Given this list of marker genes Svs4, Neurog1, Pgk2, Cdk4, Ihh, H2ax, Irs3, Tfrc, Kif20a, Eef2, D8Ertd738e, Edn1, Eif4a1, Skp1, Grin1, Gm20815, Rbm4, Tpbpa, Col4a1, Msh3, Eprs1, Rap2b, Phkg2, H1f2, Acly, Gng12, Prpf6, Polr2g, Fut4, Slc6a8, Cyp3a11 (cytochrome P450, family 3, subfamily a, polypeptide 11), Pml, Ifna15, Eif2s1, Cacnb2, Usp9x, Il17a, Ddr2, Nfe2l2, Lmnb2, Kcnh1, Zbtb16, Galt, Serpina6, Bub3, Calm3, Rela, Apoc4, Alox5ap, Kif5b, Fzd5, Itgb4, Chrm4, Rac1, Cyp19a1, Dusp7, Cntn3, Foxn1, Zyx, Xpc, Chka, Mdk, Ccl12, Iars1, Gng2, Sec23a, Eef1d, Atp5pb, Top3b, Atp2a2, Apob, Ptpn14, here is a description of the gene set: Ageing of the brain leads to impairments in cognitive and motor skills, and is the major risk factor for several common neurological disorders such as Alzheimer disease (AD) and Parkinson disease (PD). Recent studies suggest that normal brain ageing is associated with subtle morphological and functional alterations in specific neuronal circuits, as opposed to large-scale neuronal loss. In fact, ageing of the central nervous system in diverse mammalian species shares many features, such as atrophy of pyramidal neurons, synaptic atrophy, decrease of striatal dopamine receptors, accumulation of fluorescent pigments, cytoskeletal abnormalities, and reactive astrocytes and microglia. To provide the first global analysis of brain ageing at the molecular level, we used oligonucleotide arrays representing genes to determine the gene-expression profile of the ageing neocortex and cerebellum in mice. Ageing resulted in a gene-expression profile indicative of an inflammatory response, oxidative stress and reduced neurotrophic support in both brain regions. At the transcriptional level, brain ageing in mice displays parallels with human neurodegenerative disorders. Caloric restriction, which retards the ageing process in mammals, selectively attenuated the age-associated induction of genes encoding inflammatory and stress responses. Down-regulated in the neocortex of aged (30-month) mice subjected to caloric restriction since young adulthood. studied in species Mus musculus from publication Lee CK, Weindruch R, Prolla TA (PMID 10888876) Mouse Gene Set: LEE_CALORIE_RESTRICTION_NEOCORTEX_DN